The following is a description of a gene set: Mouse Gene Set: REACTOME_TRANSPORT_OF_INORGANIC_CATIONS_ANIONS_AND_AMINO_ACIDS_OLIGOPEPTIDES Transport of inorganic cations/anions and amino acids/oligopeptides studied in species Mus musculus, and this is the list of marker genes: Slc17a5, Slc25a22, Slc8b1, Slc6a14, Slc24a5 (NCBI Gene Id 317750), Slc1a3, Slc5a8, Slc15a4, Slc5a5, Slc7a8, Slc6a6, Slc12a7, Slc12a1 (solute carrier family 12, member 1), Slc43a1, Slc9a8, Slc38a3, Slc7a11, Slc9a1, Slc16a10, Slc20a2, Slc25a26, Slc25a11, Slc36a4, Slc26a9, Slc24a1, Slc6a12, Slc4a5, Slc12a4, Slc34a1, Slc1a2, Slc25a10, Slc15a1, Slc1a5, Slc38a4, Slc4a8, Slc38a1, Slc8a2, Ahcyl2, Slc9a4, Slc43a2, Slc1a6, Slc4a3, Slc8a3, Slc34a3, Slc5a12, Slc24a4, Slc4a4, Calm3 (NCBI Gene Id 97428), Slc7a7, Slc38a2, Slc24a3, Slc26a7, Slc25a18, Slc17a8, Slc9a6, Slc17a1, Slc6a19, Slc3a2 (NCBI Gene Id 17254), Slc38a5, Slc36a2, Slc34a2 (solute carrier family 34 (sodium phosphate), member 2), Slc6a20a, Slc26a6, Slc8a1, Slc24a2, Slc3a1, Slc32a1, Slc4a1, Slc1a7, Slc25a1, Slc7a9, Slc4a7, Slc7a3 (solute carrier family 7 (cationic amino acid transporter, y+ system), member 3), Slc17a6, Slc7a1, Slc9a2, Calm1, Slc25a29, Slc36a1, Slc9a3, Slc26a11, Slc26a1, Slc6a18, Slc26a3, Slc1a1, Slc7a10, Calm2, Slc20a1, Slc4a2, Slc17a7, Slc26a4, Slc15a3, Slc12a5, Ctns, Slc12a2, Slc9a9, Slc1a4, Slc7a6, Slc12a6, Slc9a7, Slc6a15, Slc4a9, Slc9a5, Slc26a2, Slc4a10, Sri, Slc7a5, Slc12a3